Given this list of marker genes Usp7, Iws1, Sart3, Supt5, Usp15, Cdk9, Epop (NCBI Gene Id 217147), Supt4b, Supt6, Supt4a, Glyr1, here is a description of the gene set: Mouse Gene Set: GOBP_TRANSCRIPTION_ELONGATION_COUPLED_CHROMATIN_REMODELING A chromatin remodeling process that reestablishes the chromatin structure following the passage of RNA polymerase II during transcription elongation, thus preventing cryptic transcription initiation. studied in species Mus musculus